The following is a description of a gene set: In this study, an extensive analysis was conducted to define meta-programs (MPs) capturing intra-tumor heterogeneity across a spectrum of tumor types. The approach utilized non-negative matrix factorization (NMF) to analyze each cell type separately within individual tumor samples. This involved the analysis of malignant cells, macrophages, fibroblasts, endothelial cells, epithelial cells, T-cells, and B-cells. NMF was executed with varying parameter values (K=4, 5, 6, 7, 8, 9), thereby generating 39 programs for each cell type per sample. Each NMF program was summarized by the top genes based on NMF coefficients.\nRobust MPs were then delineated for each cell type using a set of stringent criteria, including recurrence within the same tumor, similarity to programs in other tumors, and non-redundancy within a tumor. Subsequently, these robust NMF programs were clustered (per cell type) based on Jaccard similarity, leading to the identification of MPs associated with each cell type.\nTo enhance the quality of the MPs, a refinement steps were undertaken, involving the removal of MPs suspected of reflecting low-quality data (with an overrepresentation of ribosomal proteins or mitochondrial-encoded genes), single-study inclusion, or similarity to miss-annotated cell types. studied in species Homo sapiens from publication Gavish A, Tyler M, Greenwald AC, Hoefflin R, Simkin D, Tschernichovsky R, Galili Darnell N, Somech E, Barbolin C, Antman T, Kovarsky D, Barrett T, Gonzalez Castro LN, Halder D, Chanoch-Myers R, Laffy J, Mints M, Wider A, Tal R, Spitzer A, Hara T, Raitses-Gurevich M, Stossel C, Golan T, Tirosh A, Suvà ML, Puram SV, Tirosh I (PMID 37258682) Human Gene Set: GAVISH_3CA_METAPROGRAM_EPITHELIAL_COLON_RELATED Genes upregulated in subsets of cells of a given type within various tumors, and this is the list of marker genes: KRT20, SPINK4, ANKRD36C, JMJD1C, ST6GALNAC1, LMAN1, HPCAL1, ZG16, MGLL, SEC24D, FER1L6, ITM2A, MUC2, HSP90B1, FCGBP, TPSG1, KLK1, WFDC2, REG4, TFF3, SYTL2, PHGR1, LINC00261, CLCA1, ABCA5, REG3A, HEPACAM2, AGR2, BCAS1, F3, SPINK1, LYPD8, TFF1, PHLDA1, MLPH (NCBI Gene Id 79599), LRRC26, GSN, ELAPOR1, MT1G, AQP3, HSPA5, IFI6, DST, ITLN1, XBP1, SERPINA1, RNASE1, REP15, HES6, SLC12A2